The following is a description of a gene set: Genes expressed at higher levels in rostral regions of the cortical plate in embryonic day 14.5 mouse cortex. Mouse Gene Set: HEVNER_CORTEX_ROSTRAL_CORTICAL_PLATE studied in species Mus musculus from publication Bedogni F, Hevner RF (PMID 34321999), and this is the list of marker genes: Gabrb2, Gnal, Nin, Lrrtm3 (NCBI Gene Id 216028), Tmem108 (transmembrane protein 108), Dok5, Ppp1r14c (NCBI Gene Id 76142), Mmp17, Svbp, Rab3c, Map2k6, St3gal1, Adcyap1, Fgf18, Mc4r, Ntf3, Rbfox1, Bmpr1b, Vldlr, Smarca2, Auts2, Ptpro, Ube2ql1, Kcnq3, Ppp1r1b, Rorb, Dner, Gabra5, Fat3, Inhba, Abtb3, Osbpl6, Ndrg1, Bmpr2, Gas7, Rgs8, Bcl6, Cdr2, Hs3st3b1, Cdh10, Trim9, Robo1